Given this list of marker genes Clcn2, Park7, Bmp6, Dab2, Bmp2, Cyp11b1, Rest, Dgkq, Cyp11b2, Cacna1h, Wnt4, Bmp5 (bone morphogenetic protein 5), Dkk3, H6pd, here is a description of the gene set: The chemical reactions and pathways resulting in the formation of primary alcohols. A primary alcohol is any alcohol in which a hydroxy group, -OH, is attached to a saturated carbon atom which has either three hydrogen atoms attached to it or only one other carbon atom and two hydrogen atoms attached to it. Mouse Gene Set: GOBP_PRIMARY_ALCOHOL_BIOSYNTHETIC_PROCESS studied in species Mus musculus